Given this list of marker genes Lig1, Terf2, Pold4, Pif1, Rpa1, Pcna, Wrap53, Rfc3, Ppp6c, Shq1, Chtf8, Ccna1, Pold2, Terf1, Wrn, Pola1, Tert, Dscc1, Pold1, Nop10, Chtf18, Prim1, Pola2, Blm, Ten1, Dna2, Ctc1, Rfc1, Acd, here is a description of the gene set: Reactome Pathway: Extension of Telomeres electronically inferred by orthology from the curated human pathway part of: Telomere Maintenance This event has been computationally inferred from an event that has been demonstrated in another species.<p>The inference is based on the homology mapping from PANTHER. Briefly, reactions for which all involved PhysicalEntities (in input, output and catalyst) have a mapped orthologue/paralogue (for complexes at least 75% of components must have a mapping) are inferred to the other species. species: Mus musculus